Given this list of marker genes HRAS, FGF10, MAPK1, ATP6V0A2, ATP6V1A (NCBI Gene Id 523), FGF22, ATP6V1G2, PTPN1, ATP6AP1, FGF18, FGFR1, FGF8, PDE3B, ATP6V1D, FGF2, ATP6V0C, PTPRF, INSR, FLT3LG, ATP6V1C1, ATP6V1F, FLT3, GRB2, ATP6V0D2, PIK3CA, PIK3R4, MAPK3, ATP6V1G1, INS, THEM4, ATP6V1E1, FGFR4, FGF23, ATP6V1B2, ATP6V1G3, ATP6V1B1, FRS2, CTSD, FGF1, GRB10, SOS1, ATP6V0A1, FGF9 (fibroblast growth factor 9), TCIRG1, FGF4, FGF19, GAB2, KRAS, AKT2, ATP6V1E2, KL, ATP6V0A4, FGF6 (NCBI Gene Id 2251), PIK3R2, PDPK1, FGF5, PIK3CB, ATP6V1C2 (ATPase H+ transporting V1 subunit C2), ATP6V0E1, FGF16, KLB, NRAS, PIK3C3, FGF3, IDE, TRIB3, ATP6V0E2, ATP6V1H, FGF17, FGFR2, PIK3R1, TLR9, ATP6V0B, GAB1, ATP6V0D1, IRS1, FGF20, FGF7, IRS2, SHC1, FGFR3, PTPN11, here is a description of the gene set: Signaling by Insulin receptor Human Gene Set: REACTOME_SIGNALING_BY_INSULIN_RECEPTOR studied in species Homo sapiens